Given this list of marker genes Notch1, Jag1, Hes1, Dll4, Dll3, Rbpj, Tnfsf11, Acp1 (NCBI Gene Id 80477), Notch3, Notch4, Calcr, Dll1, Hey1, Jag2, Notch2, Nfatc1, here is a description of the gene set: Genes up-regulated in RAW 264.7 cells (macrophage) upon stimulation with TNFSF11. from publication Fukushima H, Nakao A, Okamoto F, Shin M, Kajiya H, Sakano S, Bigas A, Jimi E, Okabe K (PMID 18710934) studied in species Mus musculus Mouse Gene Set: FUKUSHIMA_TNFSF11_TARGETS Notch signaling plays a key role in various cell differentiation processes including bone homeostasis. However, the specific involvement of Notch in regulating osteoclastogenesis is still controversial. In the present study, we show that RANKL induces expression of Jagged1 and Notch2 in bone marrow macrophages during osteoclast differentiation. Suppression of Notch signaling by a selective gamma-secretase inhibitor or Notch2 short hairpin RNA suppresses RANKL-induced osteoclastogenesis. In contrast, induction of Notch signaling by Jagged1 or by ectopic expression of intracellular Notch2 enhances NFATc1 promoter activity and expression and promotes osteoclastogenesis. Finally, we found that Notch2 and p65 interact in the nuclei of RANKL-stimulated cells and that both proteins are recruited to the NFATc1 promoter, driving its expression. Taken together, our results show a new molecular cross talk between Notch and NF-kappaB pathways that is relevant in osteoclastogenesis.